Given this list of marker genes Pcna, Mbd4, Tdg-ps, Tdg, Mutyh, here is a description of the gene set: studied in species Mus musculus Mouse Gene Set: GOMF_MISMATCH_BASE_PAIR_DNA_N_GLYCOSYLASE_ACTIVITY Catalysis of the removal of single bases present in mismatches by the cleavage the N-C1' glycosidic bond between the target damaged DNA base and the deoxyribose sugar. The reaction releases a free base and leaves an apurinic/apyrimidinic (AP) site.